Given this list of marker genes FEV, MRPS26, GRHPR, HACD2, CXCR1, POP7, NDRG3, RPL13A, UFC1, TTC19, PDK3, DTD2, TMEM65, TRAM2, PRKDC, DNAJC12, ITPRIPL1, VPS26B, GIPC1, CLMN, UBE4B, RPL7A, MAML3, TRAPPC2L, RPS3A, RPL7, PLCD1, SELENOM, EIF4B, EFNA3, UBL7, NDC1, MCM6, ZFP69, GLRX5, TMEM117, B3GLCT, KLHL21, BAG5, ZNF589, ZBTB4, CNOT7, TMEM201 (transmembrane protein 201), MYCBP, SNX18, MRPL43, VAMP8, GPD1L, YIF1B, TMEM107, GID4, DTD1, CHID1, CHST13, TTC13, DYRK2, MARVELD1, AARS2, SHB (SH2 domain containing adaptor protein B), SLC26A2, TRIM32, MYO1F, CBX7, EIF4EBP1, VCL, NCAPH, CENPU, CRH, VEGFB, CD1C, LYRM7, YPEL2, FAM20C, TNFSF12, XYLT1, MBNL3, BLTP2, FOS, NHP2, SLC46A2, CACYBP, IDH2, TPM1, SUOX, INPP5A, NAXE, NIN, CLEC10A, RPA1, CACNA2D4, HSPBAP1, CFAP184, TBL1XR1, SFXN4, DUSP3, IMPDH2, PTPN4, RNF169, MSI2, STX8, GALNT18, ECHDC1, EIF2AK4, PCM1, SNX5 (NCBI Gene Id 27131), ACTMAP, CERK, MAP3K3, ADORA3, CHST14, RCBTB2, HHEX, RPL10A, DDX41 (NCBI Gene Id 96647), CIITA, BOLA3, SLC35C1, SLC46A3, GHDC, ATP5PO, ELP2, FAM118B, ZMAT4 (zinc finger matrin-type 4), CYB5R1, RRM2B, GSTK1, FES, FA2H, PRAM1, NDUFA8, MAN2A2, ABHD2, JMY, MRTFB, ACOT11, NTPCR, TIMM21, DANCR, STOML2, ZBTB20, MAPK14 (mitogen-activated protein kinase 14), HACD1, BRD3 (NCBI Gene Id 9763), FN3KRP, ATP5IF1, LTA4H, PHYHD1, FOXQ1, ZNF14, IMPA2, LRP3, FKBP9, CTNNAL1, WNT5B, PCYOX1, KYAT1, SIGIRR, TMEM9, NFIA, DNAI7, ENO2, INTS4, GAS2L3, YIF1A (NCBI Gene Id 10897), APMAP, DAAM1, RDH13, ABAT, ARL3, INKA2, PYCARD, PPP1R7, CROT, PLA2G12A, PEBP1, DPH5, ZNF641, CEBPA, TMT1A, ALDH9A1, NMT2, FADS1, HAUS4, AIFM1, SLC39A10, KCTD7, ALOX5, NUDT5, TMEM26, INTS10, GNPDA1, ICMT, SBNO1 (strawberry notch homolog 1), AP2A2, PON2, COQ8A, KIAA1143, here is a description of the gene set: from publication Napolitani G, Rinaldi A, Bertoni F, Sallusto F, Lanzavecchia A (PMID 15995707) Genes up-regulated in comparison of unstimulated dendritic cells (DC) at 0 h versus DCs stimulated with LPS (TLR4 agonist) for 8 h. species: Homo sapiens Toll like receptors (TLRs) sense microbial products and initiate adaptive immune responses by activating dendritic cells (DCs). Since pathogens may contain several agonists we asked whether different TLRs may synergize in DC activation. We report that in human and mouse DC TLR3 or TLR4 potently synergize with TLR7, TLR8 or TLR9 in the induction of selected cytokine genes. Upon synergistic stimulation, IL-12, IL-23 and Delta-4 are induced at levels 50-100 fold higher than those induced by optimal concentrations of single agonists, leading to enhanced and sustained TH1 polarizing capacity. Using microarray analysis we show that only 1.5% of the transcripts induced by single TLR agonists are synergistically regulated by combinations of TLR4 and TLR8 agonists. These results identify a combinatorial code by which DCs discriminate pathogens and provide (suggest) a rationale to design adjuvants for TH1 responses. Series_overall_design: 3 untreated, 3 treated with LPS at 2h, 3 treated with LPS at 8h, 3 treated with R848 at 2h, 3 treated with R848 at 8h, 3 treated with LPS + R848 at 2h, 3 treated with LPS + R848 at 8h Human Gene Set: GSE2706_UNSTIM_VS_8H_LPS_DC_UP